Given this list of marker genes PRKN, XBP1, SYVN1, NR1H3, MAGEA3, ABCA7, HYOU1, SVIP, UBXN1, LRRK2, PPP1R15A, DNAJB9, UBXN2A (UBX domain protein 2A), NR1H2, DDRGK1, AKT2, CLU, CREB3L1 (cAMP responsive element binding protein 3 like 1), CREBRF, AKT3, HSPA1A, UFL1, PARK7, NCK1, AQP11, LPCAT3, BFAR, HERPUD1, PPP1R15B, WFS1, ALOX5, PTPN1, MIR199A1, SELENOS, IKBKG, NCK2 (NCBI Gene Id 8440), GRINA, USP25, USP14, TXNDC12, ATF6B, CREB3, HSPA5, PDX1, RACK1, BCL2L1, OPA1, TMBIM6, SGTA, ATAD3A, AKT1, here is a description of the gene set: species: Homo sapiens Any process that stops, prevents or reduces the frequency, rate or extent of a response to endoplasmic reticulum stress. Human Gene Set: GOBP_NEGATIVE_REGULATION_OF_RESPONSE_TO_ENDOPLASMIC_RETICULUM_STRESS